The following is a description of a gene set: electronically inferred by orthology from the curated human pathway species: Mus musculus This event has been computationally inferred from an event that has been demonstrated in another species.<p>The inference is based on the homology mapping from PANTHER. Briefly, reactions for which all involved PhysicalEntities (in input, output and catalyst) have a mapped orthologue/paralogue (for complexes at least 75% of components must have a mapping) are inferred to the other species. Reactome Pathway: Neuronal System, and this is the list of marker genes: Lrfn2 (NCBI Gene Id 70530), Ppfibp1, Gngt2, Gabrr3, Gnb3, Kcnj10, Slc1a6, Kcnk3, Kcnj3, Tomt, Lrfn1, Kcna6, Kcnh6, Ptprs, Kcnab2, Ppfia2, Cacna1a, Lrrtm4 (NCBI Gene Id 243499), Kcnj12 (NCBI Gene Id 16515), Rps6ka6, Kcnh1, Lrfn3, Grin1, Gabra6, Slc6a13, Lin7b, Gabra4, Flot1, Kcnj8, Camk2b, Slitrk4, Adcy5, Slc5a7, Ppfibp2, Kcng4, Kcnk4, Prkca, Slc22a2, Sh3glb2, Shank3, Gnai1, Epb41l1, Kcnj14, Ap2b1 (adaptor-related protein complex 2, beta 1 subunit), Il1rapl2, Chrna7, Kcng2, Slc17a7, Gng7, Dlgap2, Kcnk6, Vamp2, Panx2, Syt1, Slc1a7, Kcnf1, Grip1, Camkk1, Gng11, Gng4, Kcng3, Dlg3, Dlg4, Gabrq, Grin2d, Flot2, Cacng4, Cacng3, Gls2, Kcnb2, Gng3, Lrfn4, Gng5, Homer1, Kcnj1, Gabrr1, Slc22a1, Cacnb1, Kcns1, Prkar2b (NCBI Gene Id 19088), Prkar1b, Kcnh2, Lrrc4b, Nefl, Kcnv2, Ppfia3, Kcnn3, Kcnn1, Slitrk3, Adcy7, Camk1, Slitrk5, Grin2b, Kcnc4, Panx1, Lrrtm3, Slitrk2, Stx1a, Nlgn3, Kcnj5, Gabra3, Cacna2d2, Gng8, Kcnab1, Ap2m1, Kcnh8, Kcnc3, Rtn3, Gabra1, Cplx1, Kcnv1, Grik5, Glra2, Gabrr2, Tspoap1, Kcnh5, Gjd2, Hcn4, Homer3, Kcnn4, Slc38a2, Gnb2, Hcn3, Kcnb1, Chrne, Adcy8, Slitrk1, Kcna10 (potassium voltage-gated channel, shaker-related subfamily, member 10), Gabrb3, Grin2a, Slc6a3 (solute carrier family 6 (neurotransmitter transporter, dopamine), member 3), Gnat3 (G protein subunit alpha transducin 3), Grin2c, Prkcg, Camkk2, Calm1, Gng10, Gabbr1, Slitrk6, Kcnmb1, Chrnb2, Hcn2, Kcnk16 (potassium channel, subfamily K, member 16), Htr3a, Kcnj2, Htr3b, Lrrtm2, Nsf, Gnb5, Prkacb, Chrna4, Kcna2, Gngt1 (NCBI Gene Id 14699), Aldh2, Syn3, Ap2s1, Ap2a1, Prkaca, Ptprf, Slc6a1 (solute carrier family 6 (neurotransmitter transporter, GABA), member 1), Kcnj11, Kcnq4, Lrrtm1, Rab3a, Syn1, Nlgn2, Cacna2d3 (NCBI Gene Id 12294), Cacnb3, Plcb3, Kcnk18